Given this list of marker genes TMEM120A, KCNG2 (NCBI Gene Id 26251), TNFAIP1, ARC, STEAP4, PKD2, SOD2, MICU1, CARD11, TRPV5, CRTC3, KCTD1, CARD9, ABCA3, CRTC1, ACACB, ME1, SLC1A2, ALDOA, KCTD6, KIF25, KCNA1 (NCBI Gene Id 729214), KCNS1, GLS, GOLGA2, MAPT, RIPK2, PNPT1, KCTD4, TRPA1, PKD2L1, ALAD (NCBI Gene Id 210), TRPM3, OSBPL2, KCTD13, APP, MLKL, KCNC4, GRIA3, SSBP1, HCN1, ZNF746, APPL2, KCNV1, TMEM70, DELE1, ACOT13, SYCP1, KCND3, SPAST, AQP5, PRMT1, G3BP2, KCTD19, KCNT1, ITPR3, FUS, KCTD2, THG1L, KCNA4, VSTM5, GNMT, NLRP3, LETM1, TGM2, AQP4, KCNV2 (NCBI Gene Id 169522), CBY1, ITPR1, KCTD12 (NCBI Gene Id 80710), CEP57, KCNA5, IAPP, ALDH1A2, KCNC3, SIGMAR1, MPP2, SAMD1, KCNF1, VWA1, KCTD17, KCNB1, AQP11, BEND3, PYCARD, OTOL1, PRF1, JMJD6, APIP, UPB1, CLYBL, GLRA3, P2RX7, IKZF4, POLQ, PDCD6IP, ALDH1A3, B2M, SHMT2, GBP5, TK1, MOSPD2, TRPV1, KCNA10, HLA-G, PRMT8, BLM, KCNS2, C9, NACC2, SAMHD1, KCNA2, KCND2, KCTD15, ECT2, AQP2, CALHM1, PXDN, KCNJ2, MAT1A, DEFA5, KCNC1, ATL3, ALS2, KCNA6, RYR1 (ryanodine receptor 1), ATL2, KCNRG, VPS35, NLRC4, GSDMD, KCNA7, KCTD18, KCNS3, KCNG1, KCTD11, CRTC2, NINJ1, KCTD16, EHD4, ROM1, EVL, CHMP2A, TRPM4, USP16, BASP1, KCTD5, KCTD3, KCNG3, ALOX5AP, KCTD21, CTH, KCTD7, KCTD8, TRPM2, RYR3, SCARA5, PRPH2, PRND, COMP, RBMX, PRNP, BCL10, TP53BP1, KCNA3, SHMT1, ELAVL1, RNF112, MIF, KCND1, TIFA, HPRT1, KCNJ12, TRIM72, CARD8, KCTD9, RS1, EHD3, EHD1, TRPM7, RNF135, HSD17B10, KCNB2, NLRP6, SLC1A5, SHKBP1, NLRP1, TDO2, ATL1 (atlastin GTPase 1), VASP (NCBI Gene Id 7408), KCNC2, ITLN1, PEG10, P2RX3, KCNN4, ACACA, CBR4, SGTB, KCTD10, ZBTB1, ALDH9A1, DNM1, KCTD14, AQP10, ADCY8, MCOLN1, BCL11A, KCNG4, CRYZ, here is a description of the gene set: Human Gene Set: GOBP_PROTEIN_HOMOOLIGOMERIZATION The process of creating protein oligomers, compounds composed of a small number, usually between three and ten, of identical component monomers. Oligomers may be formed by the polymerization of a number of monomers or the depolymerization of a large protein polymer. species: Homo sapiens